The following is a description of a gene set: Myeloid-derived cells comprising the tumor stroma represent a heterogeneous population of cells critical to the structure, function and growth of established cancers. We have recently found that engineering tumor-specific CD8+ T cells to secrete IL-12 (IL-12TD) can lead to striking improvements in T-cell activity against established melanomas in murine models. Surprisingly, IL-12-dependent enhancement of CD8+ T-cell anti-tumor function did not occur through direct ligation of receptors on lymphocytes or NK cells. Instead, IL-12 sensitized host bone marrow-derived tumor-stromal cells, partly through interferon-gamma, to indirectly enhance the effects of adoptively-transferred T cells. Direct presentation of antigen by tumor was not necessary, but MHC class I expression on endogenous cells was essential for IL-12 mediated anti-tumor enhancements. Upon successful treatment with IL-12TD cells, we observed the selective elimination of tumor-infiltrating CD11b+ F4/80+ macrophages, CD11b+/ClassII+/CD11c+ dendritic cells and CD11b+/Ly6C+/Ly6G- but not CD11b+/Ly6C+/Ly6G+ myeloid-derived suppressor cells within regressing lesions. These results are consistent with a model whereby IL-12 triggers the maturation of myeloid-derived cells into competent antigen cross-presenting cells. Licensed recognition of these antigens by effector T cells may in turn trigger the collapse of the tumor stroma and aid in the regression of large vascularized lesions. Human Gene Set: GSE29164_UNTREATED_VS_CD8_TCELL_AND_IL12_TREATED_MELANOMA_DAY7_DN Genes down-regulated in B16 melanoma (day 7): untreated versus mock treatment during adoptive transfer therapy. species: Homo sapiens from publication Kerkar SP, Goldszmid RS, Muranski P, Chinnasamy D, Yu Z, Reger RN, Leonardi AJ, Morgan RA, Wang E, Marincola FM, Trinchieri G, Rosenberg SA, Restifo NP (PMID 22056381), and this is the list of marker genes: TIMP3, SERINC4, ECE1, GPR132, SERPINB9, PAQR4, PTRH2, ABCB1, ELAC2, ELP5, MTMR10, ATP5IF1, PFN1, IL21R, PVT1, IFT43, PIGP, FAM98C, THYN1, FAM162A, MPST, GPANK1, CAV1, IRAG1, ZMAT5, GSX1, RHOC, GP9, TRIM7, NANOS1, CD244, PALLD, SGCE, SPP1, PPP3CC (protein phosphatase 3 catalytic subunit gamma), GDF9, TMEM123, MARCO, MTLN, CDKN1A, MARCKSL1 (NCBI Gene Id 65108), STAP2, PHLDA1, DLL4, FCRL1, HSPBP1, IPCEF1, MYC, PARD6A, HIBADH, SLC52A3, UST, SFTPD, SEC61G, DYNC2I2, ASB12 (ankyrin repeat and SOCS box containing 12), MGAT3, SLC41A1, PKIB, MMP9, NDUFA6, PLEKHG6, NPR3, YIF1B, MCRIP1, COMMD3, SIGIRR, HSPB1, C1orf53, CLU, MRPL48 (NCBI Gene Id 51642), PIN4, PRAF2, FGFR4, ZNRD2, CAPSL, VPS37B, PDLIM2, ICAM1, SGSM3, VAMP8, CD7, CLEC10A, SLC25A25, AKT1, GPD2, PIGU, TRIT1, ABCE1, USE1, SPIB, EBNA1BP2, CHST15, VEGFC, ETV5, GPCPD1, EMC9, TNFRSF8, PLAAT5, RTCB, CCDC102A, KBTBD13, CMTM8, ARK2C, C14orf180, NDUFA2, SQSTM1, DRAXIN, PDCD4, ACKR1 (atypical chemokine receptor 1 (Duffy blood group)), TES, GRM1, SLC25A33, MARVELD2, RBPMS2, AANAT, ABCC9, CTLA4, CARD10, SCGN, CD274, KITLG, IMMP2L, ACOT13, RPL22L1, MREG, HOMER2, TAP2, ECE2, C1orf54, IL12B, PFDN5, SALL3, DPYSL5, ZBTB10, DNAJB2, TRIB1, BAG1, PCP4, MPP2, ITPK1, NXT1, NDUFAF5, SNN, IL7R, PMVK, TM2D1, GTF2F2, CX3CL1, COA3, HM13, CLDN5 (NCBI Gene Id 7122), PIK3IP1, NCOA7, HOXD12, ST8SIA6, EAPP, FABP1, POLR1H, RAB11FIP4, COX8A, CHURC1 (churchill domain containing 1), NAAA, PTOV1, NDUFS6, FLRT3, PGLYRP1, RAB8A, SNRPF, APOL2, SPAG9, RABAC1, AP1B1, ASB2 (ankyrin repeat and SOCS box containing 2), NUCB2, FYN, COX6C, GRAP, TAF4B, RWDD1, RTCA, PAK1, CXCL2, UNC119, ADAMTS1, NPM1, GARIN3, DNAJB13, FGD6, NAGA, GAA, IFT22, ARMCX2, PPT1, CCR9, TSPAN9, PSTPIP1, PCBD2, JUNB, CXCR3